Given this list of marker genes STAM, ACTG1, PABPC4, CCNE1, SMS, SMAD2, PICK1, PNP, RBBP7, IFRD1, RPSA, GH1, HSPH1, PDCD2, PTPN14, EIF4E2, YWHAH, POLR1D, HMGB2, PPA1, DNAJB1, CSN3, ADM, ZNF780A, LIG1, KRT19, IL1RN, RACK1, PCNA, EEF1B2, APRT, CSRP1, SUPT4H1, TYMS, RRM1, EED, RAC1, IER2, SRM, HMOX1, RAN, MCM5, MCM2, ACLY, CDK2, H2AZ1, MCM6, GTF2F1, MCM4, PCSK7, HSPA8, CDK7, NGF, NELFE, FEN1, ATP6V1C1, here is a description of the gene set: from publication Zamora R, Vodovotz Y, Aulak KS, Kim PK, Kane JM 3rd, Alarcon L, Stuehr DJ, Billiar TR (PMID 12381414) Nitric oxide (NO) can modulate numerous genes directly; however, some genes may be modulated only in the presence of the inflammatory stimuli that increase the expression of the inducible nitric oxide synthase (iNOS). One method by which to examine changes in NO-mediated gene expression is to carry out a gene array analysis on NO-nai;ve cells. Herein, we report a gene array analysis on mRNA from iNOS-null (iNOS(-/-)) mouse hepatocytes harvested from mice exposed to NO by infection with an adenovirus expressing human iNOS (Ad-iNOS). Of the genes on this array, only approximately 200 were modulated either up or down by the increased iNOS activity according to our criteria for significance. Several clearly defined families of genes were modulated, including genes coding for proinflammatory transcription factors, cytokines, cytokine receptors, proteins associated with cell proliferation and cellular energetics, as well as proteins involved in apoptosis. Our results suggest that iNOS has a generally anti-inflammatory and anti-apoptotic role in hepatocytes but also acts to suppress proliferation and protein synthesis. The expression of iNOS results in increased expression of stress-related proteins, including heme oxygenase-1 (HO-1). We used HO-1 to confirm that a significant change identified by an analysis could be demonstrated as significant in cells and tissues. The elevation of HO-1 was confirmed at the protein level in hepatocytes in vitro. Furthermore, iNOS(-/-) mice experienced greatly increased liver injury subsequent to intestinal ischemia/reperfusion injury, associated with an inability to upregulate HO-1. This is the first study to address the global gene changes induced by iNOS in any cell type, and the findings presented herein may have clinical relevance for conditions such as septic or hemorrhagic shock in which hepatocytes, NO, and HO-1 play a crucial role. studied in species Mus musculus Up-regulated in hepatocytes upon expression of NOS2. Human Gene Set: ZAMORA_NOS2_TARGETS_UP